The following is a description of a gene set: The chemical reactions and pathways involving CDP-diacylglycerol, CDP-1,2-diacylglycerol, a substance composed of diacylglycerol in glycosidic linkage with cytidine diphosphate. It is a common intermediate in phospholipid biosynthesis. studied in species Homo sapiens Human Gene Set: GOBP_CDP_DIACYLGLYCEROL_METABOLIC_PROCESS, and this is the list of marker genes: GPAT2, AGPAT1, GPAT4, CDIPT, AGPAT5, CDS1, LCLAT1 (NCBI Gene Id 253558), GPAM, AGPAT3, CDS2, TAMM41, GPAT3, AGPAT4, AGPAT2